The following is a description of a gene set: Any process that stops, prevents or reduces the frequency, rate or extent of epithelial cell apoptotic process. Mouse Gene Set: GOBP_NEGATIVE_REGULATION_OF_EPITHELIAL_CELL_APOPTOTIC_PROCESS species: Mus musculus, and this is the list of marker genes: Myc, Ppara, Trim32, Apc, Nkx2-5, Alms1, Ttpa, Cdkn1b (NCBI Gene Id 12576), Ngf, Pdx1, Rb1, Mst1, Naip1, Tmf1, Atg7, Tcf7l2, Igf1, Itgb3bp, Lims1, Nupr1, Neurod1, Btc (betacellulin, epidermal growth factor family member), Pkhd1, Prkaa2, Serpinb13, Prkaa1, Atoh1, Igf1r, Gcm2, Mtor, Yap1, Nkx2-6, Hmox1 (NCBI Gene Id 27970), Srsf6, Cflar, Agap2, Wfs1, Pgr, Adar, Npc1, Cast, Bcl2, Mdk (NCBI Gene Id 17242), Hand2